Given this list of marker genes RAC2, ATP6V0A2, ATP6V1G2, SLC11A1, NCF4, TCIRG1, ATP6V1A, ATP6V0D2, CYBB (cytochrome b-245 beta chain), ATP6V0E1, ATP6V0A1, NCF2, NOS2, ATP6V0A4, ATP6V1H, ATP6V1B2, CYBA, ATP6V0C (ATPase H+ transporting V0 subunit c), LPO, ATP6V1E1, ATP6V1F, NOS1, ATP6V0B, MPO, ATP6V1D, ATP6V1C1, ATP6V0D1, HVCN1, NOS3, NCF1, ATP6V1G3 (ATPase H+ transporting V1 subunit G3), ATP6V1C2, ATP6V0E2, ATP6V1G1, ATP6V1E2, ATP6V1B1, here is a description of the gene set: The first line of defense against infectious agents involves an active recruitment of phagocytes to the site of infection. Recruited cells include polymorhonuclear (PMN) leukocytes (i.e., neutrophils) and monocytes/macrophages, which function together as innate immunity sentinels (Underhill DM & Ozinsky A 2002; Stuart LM & Ezekowitz RA 2005; Flannagan RS et al. 2012). Dendritic cells are also present, serving as important players in antigen presentation for ensuing adaptive responses (Savina A & Amigorena S 2007). These cell types are able to bind and engulf invading microbes into a membrane-enclosed vacuole - the phagosome, in a process termed phagocytosis. Phagocytosis can be defined as the receptor-mediated engulfment of particles greater than 0.5 micron in diameter. It is initiated by the cross-linking of host cell membrane receptors following engagement with their cognate ligands on the target surface (Underhill DM & Ozinsky A 2002; Stuart LM & Ezekowitz RA 2005; Flannagan RS et al. 2012). When engulfed by phagocytes, microorganisms are exposed to a number of host defense microbicidal events within the resulting phagosome. These include the production of reactive oxygen and nitrogen species (ROS and RNS, RONS) by specialized enzymes (Fang FC et al. 2004; Kohchi C et al. 2009; Gostner JM et al. 2013; Vatansever F et al. 2013). NADPH oxidase (NOX) complex consume oxygen to produce superoxide radical anion (O2.-) and hydrogen peroxide (H2O2). Induced NO synthase (iNOS) is involved in the production of NO, which is the primary source of all RNS in biological systems (Evans TG et al. 1996). The phagocyte NADPH oxidase and iNOS are expressed in both PMN and mononuclear phagocytes and both cell types have the capacity for phagosomal burst activity. However, the magnitude of ROS generation in neutrophils far exceeds that observed in macrophages (VanderVen BC et al. 2009). Macrophages are thought to produce considerably more RNS than neutrophils (Fang FC et al. 2004; Nathan & Shiloh 2000).<p>The presence of RONS characterized by a relatively low reactivity, such as H2O2, O2˙− or NO, has no deleterious effect on biological environment (Attia SM 2010; Weidinger A & and Kozlov AV 2015). Their activity is controlled by endogenous antioxidants (both enzymatic and non-enzymatic) that are induced by oxidative stress. However the relatively low reactive species can initiate a cascade of reactions to generate more damaging “secondary” species such as hydroxyl radical (•OH), singlet oxygen or peroxinitrite (Robinson JM 2008; Fang FC et al. 2004). These "secondary" RONS are extremely toxic causing irreversible damage to all classes of biomolecules (Weidinger A & and Kozlov AV 2015; Fang FC et al. 2004; Kohchi C et al. 2009; Gostner JM et al. 2013; Vatansever F et al. 2013).<p>Although macrophages and neutrophils use similar mechanisms for the internalization of targets, there are differences in how they perform phagocytosis and in the final outcome of the process (Tapper H & Grinstein S 1997; Vierira OV et al. 2002). Once formed, the phagosome undergoes an extensive maturation process whereby it develops into a microbicidal organelle able to eliminate the invading pathogen. Maturation involves re-modeling both the membrane of the phagosome and its luminal contents (Vierira OV et al. 2002). In macrophages, phagosome formation and maturation follows a series of strictly coordinated membrane fission/fusion events between the phagosome and compartments of the endo/lysosomal network gradually transforming the nascent phagosome into a phagolysosome, a degradative organelle endowed with potent microbicidal properties (Zimmerli S et al. 1996; Vierira OV et al. 2002). Neutrophils instead contain a large number of preformed granules such as azurophilic and specific granules that can rapidly fuse with phagosomes delivering antimicrobial substances (Karlsson A & Dahlgren C 2002; Naucler C et al. 2002; Nordenfelt P and Tapper H 2011). Phagosomal pH dynamics may also contribute to the maturation process by regulating membrane traffic events. The microbicidal activity of macrophages is characterized by progressive acidification of the lumen (down to pH 4–5) by the proton pumping vATPase. A low pH is a prerequisite for optimal enzymatic activity of most late endosomal/lysosomal hydrolases reported in macrophages. Neutrophil phagosome pH regulation differs significantly from what is observed in macrophages (Nordenfelt P and Tapper H 2011; Winterbourn CC et al. 2016). The massive activation of the oxidative burst is thought to result in early alkalization of neutrophil phagosomes which is linked to proton consumption during the generation of hydrogen peroxide (Segal AW et al. 1981; Levine AP et al. 2015). Other studies showed that neutrophil phagosome maintained neutral pH values before the pH gradually decreased (Jankowski A et al. 2002). Neutrophil phagosomes also exhibited a high proton leak, which was initiated upon activation of the NADPH oxidase, and this activation counteracted phagosomal acidification (Jankowski A et al. The module includes cell-type specific events, for example, myeloperoxidase (MPO)-mediated production of hypochlorous acid in neutrophils. It also highlights differences between phagosomal pH dynamics in neutrophils and macrophages. The module describes microbicidal activity of selective RONS such as hydroxyl radical or peroxynitrite. However, detection of any of these species in the phagosomal environment is subject to many uncertainties (Nüsse O 2011; Erard M et al. 2018). The mechanisms by which reactive oxygen/nitrogen species kill pathogens in phagocytic immune cells are still not fully understood. studied in species Homo sapiens Reactome Pathway: ROS and RNS production in phagocytes part of: Innate Immune System